The following is a description of a gene set: species: Mus musculus Any process that results in a change in state or activity of a cell (in terms of movement, secretion, enzyme production, gene expression, etc.) as a result of an oxygen radical stimulus. An oxygen radical is any oxygen species that carries a free electron; examples include hydroxyl radicals and the superoxide anion. Mouse Gene Set: GOBP_CELLULAR_RESPONSE_TO_OXYGEN_RADICAL, and this is the list of marker genes: Cd36, Mb, Prdx2, Sod2, Fbln5, Nos3, Apoa4, Sod1, Park7 (NCBI Gene Id 57320), Cygb, Adprs, Fancc, Atp7a, Mt3, Ccs, Mpo, Dhfr, Parp1, Sod3, Gch1, Prdx1, Nfe2l2, Nqo1